Given this list of marker genes PDIA6, LRP12, METTL16, OAS2, P2RY11, KLF4, AP2A2, RIN2, NTAN1 (NCBI Gene Id 123803), CEMIP, GUSBP3, SIRT1, CKMT1B, HIPK1, ADA, CD4, RNASET2, AK2, NPIPB3, SLC35F6, CHST5, ARL4C, NAMPT, VAMP5, GATM, ATP2B1, ADGRE5, WLS, WSB1, HSPA1B, ERI1, SCARB2, SPTLC2, RARA, CCDC82, KLF6, DHX58, FGL2, SETDB2, SDS, SYNPO2, WASHC2C, CD84, GPX3, SPATA13 (NCBI Gene Id 221178), TSPAN4, STAB1, WASHC4, KAT6B, MADD, C1S, RDX, CMKLR2, UNC93B1, GBP2, CD14, RIPOR1, PRCP, ZC3H12D, FNIP2, IFI27L2, ALMS1, ELMO2, SLC35E1, SPIRE1, APOC1, CDK13, TBC1D2, RSAD2, CCL19, RAD23B, DIP2A, TCAF1, ENPP2, PDGFRL, KLF5, TNFSF10, DPEP2, RBMS1, FCN1 (ficolin 1), NBN, LAIR1, TMEM140, LGALS3BP, GAB2, LPCAT1, SCARB1, SCD5, SNX2, KLF10, IL15RA, PDIA4, KLF3, CMKLR1, QKI, SLC12A7, LILRB2, TRIM5 (tripartite motif containing 5), USF2, IFIT1, TRIM38, EPSTI1, IFI44L, GADD45B, SPINK1, LINC02345, OCIAD1, STK26, BACH1, ZFYVE26, APOL3, ARRDC3, TRIM22, CTSC, XRN1, ZNF665 (NCBI Gene Id 79788), AP1B1, CES1, SLFN5, SORT1, ADGRE2, MARCKS, HLA-DMB, LGMN, SUGP2, APIP, DNASE2, TNFAIP6, IFI27 (interferon alpha inducible protein 27), GNS, BLVRA, FUS (FUS RNA binding protein), MS4A7, CHFR, DCLRE1C, TFAP2B, CCDC152, PARP10, MARCHF1, LST1, KANK1, KCNQ1, HEG1, NR3C1, CD36 (NCBI Gene Id 948), FCGR3A, HERC5, FPR1, H2BC10, LTA4H, CTSD, HERC6 (HECT and RLD domain containing E3 ubiquitin protein ligase family member 6), CREBRF, XRN2, HESX1, C1orf162, LIMD1 (NCBI Gene Id 8994), IFI44, NCF1, GPNMB, CHST13, ACBD5, UBE2L6, LCP2 (NCBI Gene Id 3937), DNAAF1, FCGR3B, IRF2BPL, LY6E, H2BC5, PINK1, TENT5A, ZNF160, PITHD1 (NCBI Gene Id 96276), APOBEC3C, IFIT3, PDE4C, MRPL30, CLIP4, CD38 (NCBI Gene Id 952), PRP4K, STOM, IFITM1, CITED2, ARAP2, CTSV, TOR1B, ENOSF1, SLC22A23, UNC45A, TMT1A, POTEKP, MYD88, FCGR1A, B4GALT5, SUGCT-AS1, PIK3AP1, CTSLP8, NCOA7, STXBP3, MXD1, PDXDC1, TLR8, RBM47, APOBEC3B, FPR2, CYP51A1, LXN, PLCL2, IFIH1, AIM2, DDAH2, FRMD4A, LZTS2, SETX, OTOA, NPL, SEMA4A, RNF228, GIMAP5, DAPP1, IFI16, RB1, MTIF3, HMOX1, REEP4, DYSF, TMEM242, MAF, LPAR6, SP110 (NCBI Gene Id 3436), MPP1, PRKACB (NCBI Gene Id 5567), ACOD1, WDR11, FUCA1, RHBDF2, TLR4, FMR1, LY86, CENPL, SLC39A8, VMP1, ZNF493, MBP, SEC24D, C2, APOBEC3G, CHN2, ACAP2, IFITM3P7, OLFML2B, CELF1, SPATA24, CTSK, PECAM1, PTGER2, RUFY3, MS4A6A, PDE8A, WTAP, CEBPD, PPA1, NMI, DSC2, MAP3K8, FCHO2, ME1, NPIPA1, RAP2B, CMPK2, PRKAR2A, CASP6, B3GNT2, KLF2, MYO1G, AFF1, MAFB, CPM, DHX9-AS1, LILRA2, GGA2, SP100, ARID5B, XAF1, GAS7, AGPS, PLEKHF2, PFKFB3, ISG20, H2BC12L, CSF3R, IFIT2, DBT, TGFBR2, NOTCH2NLA, LGALS8, SAMD9L, NUPR1, AIF1, C3AR1, TASL, ADGRE1, GAS6, NBPF14, ITPKB, IDO1, HSPA5, ARHGAP45, ALDH1A1, WWP1, LY9, SGK1, MNDA, GRAMD4, NUP62, FAS (NCBI Gene Id 355), PCM1, CPNE8, MAX, CD2AP, SOCS3, TMEM241, MARCO, RAB42, DOCK11, CCNL1, GNB4, PRR11, ATP2B1-AS1, QNG1, IFITM3, LILRB3, PTGER4, BLVRB, LPCAT3, IL10, ZEB2, ECHDC1, HAMP, SSBP2, NREP, F13A1, MS4A4A, SECTM1, CALCOCO2, MX1, CXCL9, CD302, NFAM1, COMT, SGTB (NCBI Gene Id 54557), LIMK2, TRIM14, SLC8A1, LDLRAD3, TIPARP, CXCL11, LYSMD2, HS3ST2, ARMCX1, RNF19B, KCNJ5, MACROH2A1, JAML, GBP1, USP18, ZNF207, DDX59, SAMD4A, CHI3L2, IFITM2, CAST, GCH1, ZFP36L2, PRICKLE1, ZFP36, RPAIN, CD300A, ADD3, CSGALNACT2, C1orf21, CFB, PATL1, SUCNR1 (NCBI Gene Id 56670), LACC1, CD37, CALHM6, PLEKHA2, SEPHS2, WDPCP, NEAT1, RNF213, CYP3A4, POLR2A, OAS1, DMXL2, FYB1, OASL, CALHM6-AS1, PARVG, H2AC18, TGFBI, CERT1, NBPF1, HNMT (NCBI Gene Id 3176), PLIN2, SNX18, TMEM212, SELENOP, IL18, SNHG12, SAMD9, CHPT1, KCTD12, ZNRF2, CXCL10, APOBEC3A, TALAM1, SLC26A11, SCCPDH, HAUS2, MAML2, CCR5, MTPAP, FAM20A, KLHDC8B, PLA2G15, ARHGAP12, MALAT1, HNRNPA2B1, HRH1 (NCBI Gene Id 3269), NT5C3A, RIGI, MUCL1, SLC16A6, HSCB, NRIP1, SAT1, RBFOX1, PRKD2, LYN, DUSP1, SLC46A3, UBXN2A, HIRA, MX2, IFIT5, BCL6, CD163, BNIP3, SIGLEC1, SH3PXD2A, SERPING1, OAS3, ABCC5, SPN, LYSMD3, NOTCH2, here is a description of the gene set: from publication Fulcher JA, Hashimi ST, Levroney EL, Pang M, Gurney KB, Baum LG, Lee B (PMID 16785517) Human Gene Set: FULCHER_INFLAMMATORY_RESPONSE_LECTIN_VS_LPS_DN Genes down-regulated in monocyte-derived dendritic cells (MDDC) after stimulation with galecin-1 (lectin, LGALS1) compared to that with bacterial lipopolysaccharide (LPS). Dendritic cells (DCs) are potent mediators of the immune response, and can be activated by exogenous pathogen components. Galectin-1 is a member of the conserved beta-galactoside-binding lectin family that binds galactoside residues on cell surface glycoconjugates. Galectin-1 is known to play a role in immune regulation via action on multiple immune cells. However, its effects on human DCs are unknown. In this study, we show that galectin-1 induces a phenotypic and functional maturation in human monocyte-derived DCs (MDDCs) similar to but distinct from the activity of the exogenous pathogen stimuli, LPS. Immature human MDDCs exposed to galectin-1 up-regulated cell surface markers characteristic of DC maturation (CD40, CD83, CD86, and HLA-DR), secreted high levels of IL-6 and TNF-alpha, stimulated T cell proliferation, and showed reduced endocytic capacity, similar to LPS-matured MDDCs. However, unlike LPS-matured DCs, galectin-1-treated MDDCs did not produce the Th1-polarizing cytokine IL-12. Microarray analysis revealed that in addition to modulating many of the same DC maturation genes as LPS, galectin-1 also uniquely up-regulated a significant subset of genes related to cell migration through the extracellular matrix (ECM). Indeed, compared with LPS, galectin-1-treated human MDDCs exhibited significantly better chemotactic migration through Matrigel, an in vitro ECM model. Our findings show that galectin-1 is a novel endogenous activator of human MDDCs that up-regulates a significant subset of genes distinct from those regulated by a model exogenous stimulus (LPS). One unique effect of galectin-1 is to increase DC migration through the ECM, suggesting that galectin-1 may be an important component in initiating an immune response. studied in species Homo sapiens